The following is a description of a gene set: studied in species Mus musculus Any process involved in the carrying out of an immune response by a lymphocyte. Mouse Gene Set: GOBP_LYMPHOCYTE_MEDIATED_IMMUNITY, and this is the list of marker genes: Fcgr1, C9 (NCBI Gene Id 12279), Exosc6, Klrc1, Cebpg, Ighv9-4, Lyst, Clec2d, H2-T22, Ifng, Icosl, Ighv1-76, Trpm4, Ighv4-1, Smad7, Calhm6, Tnfsf13, Icam1, Fcrlb, Ighv5-4, Prkcz, Ahr, Azgp1, Bcl10, Dlg1, Cr1l (NCBI Gene Id 12946), Ighv5-9, Shld1, Ighv1-82, Jag1, Ctsc, Ighv9-2, Ighv1-55, Klhl22, H2-M10.5, Cadm1, C1ra, Il27ra, Msh2, Susd4, Hspd1, Il12b, Cd28, Ighv6-5, Tnf, Atad5, Aire, Igha, Fcer1a, C8g, Ighv14-1, Ighv1-24, Cd74, Mill1, Ighv3-8, Nkg7, Nbn, C1rb, Ulbp3, Pms2, Lep, Fcmr, Ighv1-62-3, Pik3r6 (phosphoinositide-3-kinase regulatory subunit 5), H2-M11, Fzd5, Nlrp3, Kmt5c, Ighv6-4, Stx7, Mr1, Malt1, Ighv1-77, Arl8b, Ighv7-1, Inpp5d, Csf2rb2, C1rl, Ighv1-56, Pirb, Ephb6, Cd55b, Ighv2-9, Fadd, Klrb1, Ighv14-4, Cd40, Zbtb1, Ighv8-13, C1qa, Cd19, Ighv1-54, Myd88, Hfe, Serpinb9h, Lig4, Fcer2a, Parp3, Ighv9-1, Gzmb, P2rx7, Serpinb9, Ighv1-7 (NCBI Gene Id 677484), Ighv8-12, Ighv1-72, Lgals9, Cdh17, Pagr1a, Arrb2, Zp3, Rif1, Ighm, Klre1, Ighv2-5, Shld2, Il18r1, Rsad2, H2-M9, Iglc2, Hprt1, H2-T13, Kctd9, Sh2d1b2, Mbl1, Ighv1-71, H2-D1, Ighv1-85, H2-M5, Ighv10-3, Emp2, Hpx, Fcgr3, Iglc1, Ighv5-6, Ighv16-1, Tgfb1, Ighv8-4, Ighv5-12-4, Clec12b, Ighv3-6, Lilrb4a, Cd55, Gata3, Klrb1f, Vsir, Clec4g, Il31ra, C8a, Il20rb, Ighv1-49, Fgl2, Ighv1-64, Ighv1-26, Treml4, Tnfrsf1b, Nfkbiz, Stat5b, Pdcd1, C1s1, Card9, Ighv2-7, Prf1, Pik3r1, Xcl1, Tap1, H2-M10.1, Ctsh, Il6, H2-T23, Fcgr2b, Ulbp1, Arid5a, Ndfip1, Sh2d1b1, Il4, Arg1, Traf6, Muc4, Ighv1-42, Mbl2, Il4i1 (NCBI Gene Id 15088), Il18, Hmgb1, Rnf19b (NCBI Gene Id 75267), Paxip1, 6030468B19Rik, Spn, C8b, C4bp, Ptprc, Ager, Ighv1-50, Ighv1-23, Ighv2-6-8, Ighv1-81, BC037156, Ighv3-5, Rftn1, Ighv14-3, Ighv12-3, Xrcc4, Havcr2, Traf3ip2, Dpp4, Ufl1, Ighg3, Gimap5, Stard7, Fbxo38, H2-DMa, Igll1, Ighv1-58, Igf2, Ighv1-67, Cfh, Sh2d1a, H2-T5, Ighv2-6, Msh6, Mir181b-2, Klrc2, Slc22a13, Il7r, Kmt5b, Cd70 (CD70 antigen), B2m, Il12a, Lta, Fcgr4, Cd2, H2-Q6, H60b, Hspa8, Crp, Ighv1-22, Stat5a, H2-Q2, Rnf8 (ring finger protein 8), Kdm5d, Ighv5-17, Ighd, Tfrc, Il25, Ighv8-5, Ccr6, Cd160, Ebag9, Ighg2c, Ighv11-1, H2-T3, Trp53bp1, Map3k7, Ighv1-15, Ighg1 (NCBI Gene Id 16017), Fosl2, Tap2, Shld3, Klrd1, Ighv1-80, Sash3, Zp3r, Klri1, Slc11a1, Ighv3-1, Pnp, Exosc3, Gba1, Fut7, Was, Lag3, Hmces, Ighv8-6, H2-M3, Rab27a, Klrc3, Cd226, Dennd1b, Kdelr1, Crtam, Ighv1-11, Nectin4, H2-K1, H2-Q7, Ighv1-84, Pvr, Clcf1, Cd40lg, Klrb1a, Ighv7-3, Cd24a, Klrb1b (NCBI Gene Id 80782), Cfi, Pou2f2, Unc93b1, Klrk1, Ighv11-2, Nckap1l, Ptpn6, Lamp1, Ighv14-2, Mir181b-1, Tcirg1, Ighv1-66, Crlf2, Foxj1, Ighv1-47, C1qbp, Ighv8-9, Clnk, Prkaa1, Ighv1-34, Ighv8-2, H2-Ea (histocompatibility 2, class II antigen E alpha), Tbx21, Ighv1-16, H2-M10.4, Cd81, Mlh1, Nod2, Il18rap, Fas, Ighv1-63, Cd46, Slamf1, Gzmn, Gzmc (NCBI Gene Id 14940), Serpinb9e, Masp2, Ighv3-4 (immunoglobulin heavy variable V3-4), Grb2, Serping1, Gimap3, Plekhm2, Ighv3-3, Il1r1, Ripk3, Ncr3-ps, Ccl20, Cd274, Klrb1c, Raet1d, Il9r, Ighv2-4, Hcst, Ighv1-53, Ighv1-78, Batf, H2-Q1, Prdx1, Traf2, Ighv2-3, Il1b, Crk, Rasgrp4, Ighv13-2, Trex1, Cd1d1 (NCBI Gene Id 99710), Ighv1-4, Cd1d2, H2-Q10, Serpinb9g, Il21, Ighv1-39, Ighv2-2, Serpinb9f, C2, Pcyt1a, H60c, Nsd2, Raet1e, Ighv5-12, Stat6, Foxp3, H2-M10.2, Ighv1-5, Trem2, Ighv2-9-1, Pik3cb, Rnf168, Aplf, Slamf6, Ighv8-8, Il2rb, Bcl3, Slfn2, Sanbr, Cd8a, Enpp1, Gcnt3, C1qb, H2-M10.3, Vav1, Klri2, C1s2, Coro1a, Ung, Ap1g1, Btk, Fcer1g, Ccr2, Cyrib, Rasgrp1, C3, Il23a, Ceacam1, Ighv6-3, H2-T24, Csf2rb, Bcl6, Ppp3cb, Gapt, 2410137M14Rik, Supt6, Ighv1-31, Nectin2, Kif5b, Gfer, Gzmm, Il9, H2-T15 (histocompatibility 2, T region locus 15), Exo1, Gfus, Hc, H2-Q4, Ighv10-1, Ifnb1, Ercc1, Serpinb9d, Lilrb4b, Stx11, Tnfsf4, Ighv9-3, Il4ra, Ighe, Ighv5-16 (NCBI Gene Id 633568), Ighg2b, C4b, Serpinb9b, Cd80, H2-M2, Iglc3, Swap70, Prkcd, Ighv1-12 (NCBI Gene Id 629860), H2-M1, Cd96, Cr2, Ighv6-7, Ighv6-6, Ighv1-61, Slc15a4, Ywhag, Irf7, Ighv1-75, Myo1g, Aicda, Il2, Ighv1-43, C1qc, Mad2l2, Unc13d, Ighv8-11, H2-M10.6, Il13ra2, Serpinb9c, Dusp22